The following is a description of a gene set: species: Homo sapiens Pulmonary lymphangiectasia Abnormal dilatation of the pulmonary lymphatic vessels. Lymphatic fluid in the lung is derived from normal leakage of fluid out of the blood capillaries in the lung. In pulmonary lymphangiectasia, the pulmonary lymphatics are not properly connected and become dilated with fluid. Human Gene Set: HP_PULMONARY_LYMPHANGIECTASIA, and this is the list of marker genes: CCBE1, ADAMTS3, SOX18, FAT4, FOXF1